The following is a description of a gene set: Human Gene Set: GOBP_RIBOSE_PHOSPHATE_BIOSYNTHETIC_PROCESS studied in species Homo sapiens The chemical reactions and pathways resulting in the formation of ribose phosphate, any phosphorylated ribose sugar., and this is the list of marker genes: ADCY2, ADA, PID1, TGFB1, DNAJC30, NUDT2, PAPSS2, COX11, LIPA, CTPS1, NME2P1, AK3 (NCBI Gene Id 50808), PRPS1, RFK, NPPA, CTPS2, SDHB, ATP5MJ, ATP5F1A, UCK1, MAP2K1, CMPK1, DMAC2L, NDUFS7, NDUFB8, GUCY1B1, UCKL1, PAICS, PINK1, ATP5MG, NDUFS8, PPARA, ATP5MF, NDUFS5, NPPB, NDUFB11, NDUFS1, AK5, SLC25A13 (solute carrier family 25 member 13), TREM2, NDUFA2, ADCY6, NDUFA8, ATIC, MIR675, SDHA, ALDOA, ATP5F1B, ATP5MC2, ADSS1, IL4, UCK2, NDUFB6, AMPD2, MT-ND4, ADCY3, NDUFB4 (NCBI Gene Id 727762), STOML2, NME1, ATP5PO, ADCY1, NPR2, VPS9D1, MTHFD1, ADCY9, STAT3, NME5, ATP5IF1, NDUFB7, NDUFC1, NDUFB3, NDUFB2, DCK, PFAS, ATP5MC1, NDUFC2, ATP5MC3, ATP5MGL, UMPS, MT-ND6, ATP5PB, GART, NDUFS4, NME4, NDUFA5, ADCY7, NDUFB9, G6PD, ATP5PD, SDHC, NME9, PRPS2, NDUFA11, LDHC, PRPSAP2, ADCY5, MT-ATP8, DHODH, IMPDH1, AK2, CDA, IMPDH2, ATP5F1C, PAPSS1, NME7, NDUFV2, ADSL, NDUFA6, TAFAZZIN, SPHK2, NDUFA3, ADCY8, PRPS1L1, MT-ND5, AMPD1, MT-ND3, PARP1, GUCY1A2, UQCC3, MT-ND2, ANTKMT, ADSS2, NME3, NDUFS2, ATP6V0C, ATP5PF, ADCY10, NDUFV1, SDHD, NDUFAB1, HPRT1 (NCBI Gene Id 3251), ATPSCKMT, NDUFA13, NME6, GUK1, NDUFS6, AK1, PRPSAP1, AMPD3, CAD, ENO1, NDUFA7, NDUFV3, NDUFA12, NDUFS3, NDUFB1, PPAT, ADK, NDUFB10, ADCY4, TMSB4X, APRT, NDUFA9, UPP1, UPRT, GUCY2C, AK9, NDUFA1, GMPS, GUCY1A1, PRKN, MT-ATP6, NDUFA10, ATP5ME, LETMD1, GUCY2F, ATP5F1D, MT-ND4L (mitochondrially encoded NADH:ubiquinone oxidoreductase core subunit 4L), GUCY2D, ATP5F1EP2, NPR1, UPP2, NDUFB5, NME2, AK4 (adenylate kinase 4), ATP5MK, FAM3A, ATP5F1E, NPPC, PRKAG2, MT-ND1, VCP